The following is a description of a gene set: studied in species Homo sapiens Any process that modulates the frequency, rate or extent of neutrophil activation. Human Gene Set: GOBP_REGULATION_OF_NEUTROPHIL_ACTIVATION, and this is the list of marker genes: PLPP6, TNF, PTPN11, GRN, FCGR2B, CD300A, MIR125A, PTPN6, CLEC12A, SRC, IL16, PLA2G2A